Given this list of marker genes DNM2, ODC1 (ornithine decarboxylase 1), BIN1, SLC16A2, MTMR14, MYF6, RYR1, FOCAD, PIGN, here is a description of the gene set: The presence of an abnormally large skull with onset at birth. Human Gene Set: HP_MACROCEPHALY_AT_BIRTH species: Homo sapiens Macrocephaly at birth